The following is a description of a gene set: Mouse Gene Set: REACTOME_FORMATION_OF_SENESCENCE_ASSOCIATED_HETEROCHROMATIN_FOCI_SAHF Formation of Senescence-Associated Heterochromatin Foci (SAHF) studied in species Mus musculus, and this is the list of marker genes: Lmnb1, Hmga1b, H1f2, H1f4, Ep400, H1f1, Hmga1, Cabin1, H1f5, Rb1, Trp53, Hmga2, Ubn1, Asf1a, H1f0, Hira